The following is a description of a gene set: studied in species Homo sapiens Reactome Pathway: NTF4 activates NTRK2 (TRKB) signaling Signaling by the neurotrophin receptor tyrosine kinase NTRK2 (TRKB) can be activated by binding to neurotrophin-4 (NTF4, also known as NT-4), which functions as a ligand for NTRK2. Binding to NTF4 triggers NTRK2 dimerization and trans-autophosphorylation of NTRK2 dimers on conserved tyrosine residues in the cytoplasmic tail of the receptor. Phosphorylated tyrosine residues subsequently serve as docking sites for recruitment of effector proteins that trigger downstream signaling cascades. part of: Signaling by NTRK2 (TRKB), and this is the list of marker genes: NTRK2, NTF4